Given this list of marker genes HPX, TK1, DAPK1, CCT6A, SAA1, YWHAH, RHOU, DNAJB9, SPCS3, KRAS, SYNCRIP, TOP2A, IL6, DPCD, POLA1, GHRHR, KIF20A (kinesin family member 20A), MCM7, MXD3, LIG1, KCNE2, PSPH, NASP, ELF3, YIPF7, KL, CHORDC1, UGDH, DEDD2, DYNLL1, HSP90AB1, PDE4B, ECT2, FIBIN, ATG16L1, BUB1, MED21, VMP1, HSPB8, SEC11A, HSPA4L, ANLN, PKNOX1, CENPA, BARX1, MAP3K6, DNAJA1, FSIP1, RBP4, GPX2, SPHK2, ITIH4, PA2G4, MLEC, DHX8, BANP, PALS2, XPO1, REXO4 (NCBI Gene Id 90950), FXR1, PRIM1, PBK, GSPT1, RRM2, MRPS6, BIRC6, XPNPEP1, UBR2, PHLDA1, HOMER2, RBM47, CRELD2, CCNA2, HSPA8, CD14, SLC25A6, CCNE2, SLC23A2, WFDC1, ID1, FST, YJEFN3, SCT, SLF2, RPS2, FEN1 (NCBI Gene Id 5882), GFPT2, CHDH, ILF2, HSPD1, TSHZ1, ERLIN1, HSPE1, HSPB1, GCLM, ZNF623, ASF1B, MMP3, HSPH1, BAG2, HSPA5, KRT8, AHSA1, ADORA2B, EIF4E (eukaryotic translation initiation factor 4E), PTHLH, DR1, CEBPB, PRDX6, PSAT1, SEC14L1, STIP1, RAD51, CSTF3, MRPS7, MTCH2, SPSB1, TNFSF9, KCTD11, LUZP1, CXCL17 (C-X-C motif chemokine ligand 17), UBE2C, SLBP, SPP1, MANF, NEDD1, HAT1, PON3, PRC1, PAPLN, PPA1, CACYBP, PLOD1, DNAJB1, UBQLN1, STBD1, NAMPT, RBM15, FKBP5, BAG3, CTPS1, SEC61B, H2AX, CDK1, SRPK1, POLE2 (DNA polymerase epsilon 2, accessory subunit), UBE2F, SFN, BATF, LCN2, TNFRSF1B, PPP1R10, SEBOX (NCBI Gene Id 651321), PHYHD1, RANBP1, NDC1, NPR3, ESRP2, CLIP4, STAM, MAT1A, FAM120B, GDPD3, SLC7A6, NUSAP1, FOXJ1, CEP55, NPAS3, ERRFI1, SLC35B1, SERPINH1, TCEAL9, MRM3, PCLAF, PMVK, TOP1, LDHA, AREG, MGP, FOXK2, SPC25, KLF15, PTGS2, PIGA, SOCS3, MCM5, ABHD14A, CDKN1A, TRMT1L, FASN, TLCD4, ZC3H3, RRM1, BPNT1, DNAJA4, TIMP1, CRELD1, DDIT3 (DNA damage inducible transcript 3), GCLC, EDEM3 (NCBI Gene Id 87240), here is a description of the gene set: from publication Bauer AK, Rondini EA, Hummel KA, Degraff LM, Walker C, Jedlicka AE, Kleeberger SR (PMID 21543283) studied in species Homo sapiens We previously identified toll-like receptor 4 (Tlr4) as a candidate gene responsible for ozone (O3)-induced pulmonary hyperpermeability and inflammation. The objective of this study was to determine the mechanism through which TLR4 modulates O3-induced pulmonary responses and to utilize transcriptomics to determine TLR4 effector molecules. C3H/HeJ (HeJ; Tlr4 mutant) and C3H/HeOuJ (OuJ; Tlr4 normal), mice were exposed continuously to 0.3 ppm O3 or filtered air for 6, 24, 48 or 72 hr. Affymetrix Mouse430A_MOE gene arrays were used to analyze lung homogenates from HeJ and OuJ mice followed using a bioinformatic analysis. Inflammation was assessed by bronchoalveolar lavage and molecular analysis by ELISA, immunoblotting, and transcription factor activity. TLR4 signals through both the MYD88-dependent and independent pathways in OuJ mice, which involves MAP kinase activation, NF-kappaB, AP-1, and KC. Microarray analyses identifiedTLR4 responsive genes for strain and time in OuJ versus HeJ mice (p<0.05). One significantly upregulated cluster of genes in OuJ were the heat shock proteins (Hspa1b; Hsp70), Hsp90ab1). Furthermore, O3-induced expression of HSP70 protein was increased in OuJ compared to HeJ mice following 24-48 h O3. Moreover, BAL polymorphonuclear leukocytes (PMN) and total protein were significantly reduced in response to O3 in Hspa1a/Hspa1btm1Dix (Hsp70-/-) compared to Hsp70+/+ mice (p<0.05). TLR4 signaling (MYD88-dependent), ERK1/2, AP-1 activity, and KC protein content were also significantly reduced after O3 exposure in Hsp70-/- compared to Hsp70+/+ mice (p<0.05). These studies suggest that HSP70 is involved in the regulation of O3-induced lung inflammation through the TLR4 pathway and provide evidence that HSP70 is an endogenous in vivo TLR4 ligand. Human Gene Set: GSE20715_0H_VS_48H_OZONE_LUNG_DN Genes down-regulated in comparison of lung tissue from wild type mice subjected to ozone for 0 h versus that from wild type mice subjected to ozone for 48 h.